Given this list of marker genes TP53, TGFB1, VSX2, KCTD11, MIR137, PTN (NCBI Gene Id 5764), PROX1, VAX1 (ventral anterior homeobox 1), NF1, CTNNA1, PAX6, BTG2, KIFAP3, GATA2, here is a description of the gene set: Any process that stops, prevents, or reduces the frequency, rate or extent of the proliferation of neuroblasts. species: Homo sapiens Human Gene Set: GOBP_NEGATIVE_REGULATION_OF_NEUROBLAST_PROLIFERATION